Given this list of marker genes Pthlh (NCBI Gene Id 19227), Atf4, Slc39a8, Ache, Crb2, Dlk1, Sox6, Slc37a4, Dnaja3 (NCBI Gene Id 98023), Slc1a5, Zfp251, Cfap70, Prom1, Hdac6, Crtc3, Mir379, Picalm, Adam17, Ccl2, Fcgr2b, Atp1b2, Slc4a2, Acvr1c, Cdh23, Rac2, Mir134, Rps24, Mup11, Tspan9, Ctnnb1, Smad5, Stat5b, Prkaa1, Bmi1, Ogt, Gpr137b, Gpr183, Sit1, Ceacam1, Slc25a44, Tsc22d3, Jmjd6, Kdm6b (KDM1 lysine (K)-specific demethylase 6B), Prrc1, Lrp6, Car2, Kras, Mir140, Gpam, Actn3, Ehbp1l1, Naglu, Gnas, Smarca4, Sln, Bcr, Cebpg, Ebf2, Prcp, Gpr82, Acaca, Glul, Scnn1b, C1qtnf9, Neurod1, Nphp4, Elovl3, Skil, Adipoq, Gimap5, Zfp423, Stk11, Adora2a, Mir487b, Atf2, Ripk3, Anxa1, Hoxa5, Gprasp2, Nr1d1, Mthfd1, Cckar, Mak, Mpl, Nr1d2, Oas1c, Pemt, Kitl, Decr1, Acadvl, Muc4, Slc22a5, Plcl2, Ampd3, Hmox1, Epsti1, Tmem63b, Med1 (NCBI Gene Id 19014), Tlr9, Flvcr1, Plcl1, Ildr2, Mfsd2a, Igf2bp2, Zc3h8, Ppp2ca, Tnf, Pla2g2a (NCBI Gene Id 18780), Sod2, Rc3h2, Ppp1r13l, Gcnt2, Ptges, Arhgef5, Tmprss6, Nr1h2, Slc28a3, Stk39, Tnfrsf13b, Sh3gl2, Wnt10b, Ccr5 (C-C motif chemokine receptor 5), Nf1, Mir329, Smarca2, Myb, Adcyap1, Tnfrsf4, Ccl5, Mir412, Il1a, L3mbtl3, Siva1, Ank1 (ankyrin 1, erythroid), Nt5e, Abcb1a, Calcr, Rps6, Rhd, Pth2r, Acin1, Hoxc10, Il7, Slc27a1, Il15, Vps13b, Rassf2, Sos2, Stat4 (NCBI Gene Id 20849), Zbtb7b, Inpp5d, Nod2, Ireb2, Zbtb18, Spp1, Abhd6, Mir323, Epg5, Ltbp3, Slc22a21, Pnpla3, Add1, Lat, Col14a1, Hoxb6, Il6, Dyrk3, Ehmt1, Wfs1, Cdk5rap3, Sucnr1, Isg15, Minar2, Irf4, Kmt2a, Vpreb1b, Dll1, Wwtr1, Apc, Rrn3, P4htm, Etv2, Axin1, Jak2, Fmo4, Hfe, Dock11, Atxn2, Ercc2, Gfi1b, Ets1, P2rx7, Suv39h1, Emcn, Nox3, Mup3, Idua, Csf1, Ccr4 (C-C motif chemokine receptor 4), Ikbkb, Cd47, Ubap2l (NCBI Gene Id 97055), Tns2, Arap1, Rps19, Letmd1, Bbs2, Plac8, Exoc5, Hba-a2, Ceacam2, Rbp4, Spta1, Mir122, Hnf1a, Vgf, Col3a1, Adam8, Hbb-bs, Fcor, Lmo2, Cd44, Slc25a38, Pbld1, Slc46a2, Mir1197, Abcg2, Nkiras2, Ptgs2, Slc15a4, Mir485, Hamp, Bpgm, Cntn2, Afdn, Nkx2-3, Gpx2, Cxcr2, Akr1b1, Lsr, Hadh, Heatr3, Mir150, Cartpt, Cdhr1, Tfrc, Ddit3, Oas1g, Slc11a2, Mfn2, Ikbkg, Crocc, Fance (NCBI Gene Id 72775), Cdh2, Xiap, Tulp1, Ush1c, Gpr15lg, Eif4g1, Twist1, Brd1, Col2a1, Fech, Plcb1, Fbxo21, Adar, Aipl1, Slc48a1, Bmp4, B2m, Prlh, Lcn2, Septin4, Ascl3, Ccdc154, Rps14, Whrn, Nr1h3, Cpt2, Cfh, Tjp1, Ppp3cb, Acot13, Siglec15, Mir411, Abcb10, Atp5if1, Rps17, Inpp5k, Il20rb, Flt3l, Zfp36l1, Cngb1, Il20ra, Bpifa1, Inhba, Trf, Umod, Pacs1, Nova1, Fmo2, Adgrf4, Mtf1, Ndn, Alas2, Mfhas1, Il4ra, Aqp4, Aqp2, Prkdc, Akt3, Mir654, Acvr2b, Pirb, Trpv1, Sirt1, Mir666, Trim58, Ucp2, Pde6a, Itgb3, Bbip1, Acp5, Scnn1g, Cntnap2, Slc35d3, Bax, Mapk14, Pbld2, Gpr137, Nfe2l1, Il10ra, Mllt6, Bmp6, Cidea, Vegfa, Oas1a, Kdm3a, Hspa1b, Lep, Muc13, Clic5, Adgrg1, Racgap1, Ubash3b (NCBI Gene Id 72828), Pctp, Dync1h1, Alas1, Wdr48, Def8 (differentially expressed in FDCP 8), Ptgs1, Cxcr4, Atp6v1b1, Slc7a11, Ybx2, Htr2a, Itgam, Nr4a3 (NCBI Gene Id 18124), Bsg (NCBI Gene Id 12215), Fstl1, Esrrg, Mup1, Cadps2, Acadl, Mecom, Strap, Oxt, Wdr36, Foxa3, Mpig6b, Gpr55, Pknox1, Ezh2, Slc4a1, Dio2, Dnase2a, Adora1, Scd1, Ldb1, Rhag, Srf, Abcb1b, Stat5a, G6pdx, Rag1, Apbb2, Mir380, Ahr, Bap1, Mip, Dock10, Gimap3, Pik3ca, Il18r1, Mbl2, Ocln, Fcer1g, Gpx1, Selenow, Piwil4, Mrap2, Lrrk1, Lpcat1, Cx3cr1 (C-X3-C motif chemokine receptor 1), Cyp19a1, Gata3 (GATA binding protein 3), Card11, Ankrd54, Tnfrsf17, Gfral, Hmgb1, Spi1, Ankle1, Nckap1l, Tgfbr3, Nemp1, Mir541 (microRNA 541), Pla2g10, Oas1e, Zfp36, Map7, Prlr, Cd24a, Mir451a, Pdgfrb, Mir667, Ncstn, Tnfrsf13c, Ildr1, Iqcb1, Mir376a, Pla2g4a, Tnfsf4, Ppard, Emx1 (NCBI Gene Id 13796), Ahsg, Ednrb, Cib2, Mir1193, Cftr, Aqp7, Mir369, Nppb, Nova2, Syk, Guca2b, Hspa9, Cep290, Edn2, Bloc1s6, Has2, Adipor1, Ufl1, Oma1, Mafb, Ccdc66, Cytl1, Trgc1, Lama4, Sh2b2, Cd38, Tmem14c, Prdm14, Nxnl2, Ccr2, Gpr39, Kcnj1, Prdx2, Hif1a, Hjv, Ifnb1, Mir539, Ap3b1, Tfe3, Abcc8, Nbea, Ptger3, Pdgfc, Mir494, Bscl2, Mir453, Hcar2, Poc1b, Lca5, Ptpn2, Aqp6, Ccr7, Flcn, Gigyf2, Foxc2, Wnk3, Nos3, Kif3a, Abat, Nfkbiz, Sart3, Scnn1a, Col9a1, Rasal2, Ccdc198, Epb42, Mir496b, Il2ra (interleukin 2 receptor, alpha chain), Vhl, Gapt, Rcor1, Ampd2, Adipor2, Sash3 (SAM and SH3 domain containing 3), Itgb1, Hephl1, Hcrt, Il1b, Armcx1, Mir142hg, Fbxl5, Mir451b, Mc4r, Tub, Fam210b, Mkks, Per2, Erbb4, Fosl2, Exoc6, Ldb2, Gpi1, Zeb2, Nlrp6, Mir17, Bmp8b, Cln8, Gdf3, Rheb, Mir409, Nphp3, Dbh, Uba5, Zfp516, Mir299b, Foxp3, Pwwp2b, Rbfox2, Ctns, Myct1, Itpkb, Bbs10, Cdin1, Fsip1, Senp1, Apoe, Ubb, Tex15, Adamts5, Rab3d, Ghrl, Tgfb2, Bak1 (NCBI Gene Id 12018), Egr1, Cnot3, Fto, Klf13, Gm36723, Brinp1 (bone morphogenic protein/retinoic acid inducible neural specific 1), Mks1, Wnk4, Col11a2, Apln, Slc1a1, Mertk, C1qtnf4, Coro1a, Nrdc, Tcirg1, Btk, Gpr174, Abl1, Adrb1, Cldn5 (NCBI Gene Id 21920), Sox4, Crtc1, Bcl6, Adrb2, Notch1, Lmo1, Trim10, Clrn1, Btbd9, Nle1, Smo, Fmo1, Cav1, Fgf21 (fibroblast growth factor 21), Avp, Usp45, Ypel4, Vpreb1a, Men1, Sco1, Adcy6, Vstm4, Trpm8, Ppargc1a, Znhit1, Enpp1, Bola3, Ercc6, Col6a1, Rp1, Akt1, Sfxn5, Heph, Ankrd11, Odad3, Oas1h, Hba-x, Hc, Napepld, Vps13a, Bcl2l11, Pantr2, Pik3cd, Napsa, Gnasas1, Bdkrb2, Tle3, Pparg, Muc5ac, Perp, Caml, Prdx5, Irx3, Tspo2, Foxc1 (NCBI Gene Id 17300), Cxcl5, Grb10, Pgam5, Oas1b, Mfap2 (microfibrillar-associated protein 2), Mir376c, Fshb, Setd1a, Tpp1, Cybrd1, Fcgr4, Tcea1, Cxadr, Sfxn1, Fam3d, Tlr4, Trpv2, Rab7, Gba1, F2r, Creb1, Carmil2, Map2k6, Ext2 (exostosin glycosyltransferase 2), Oas1f, Slc11a1, Epo, Thra, Mir300, Pmaip1, Ctsk (cathepsin K), Lilrb4a, Ezh1, Tff2, Aqp3 (NCBI Gene Id 230080), Neo1, Ptk2b, Hmga1, Pth, Pdk4, Tmem64, Qki, Fancc, Ncor1, Mef2c, Il1rn, Rp1l1, Hcls1, Sod1, Ccnb2, Lyn, Prkab1, Smap1, G0s2, Ctss, Tnfsf11, Ncdn, Alms1, Sqstm1, Gdf15, Ppp2r3c, Adgrv1, Pkn1, Chst3, Acvr2a, Crispld1, Lepr, Zfp830, Fas, Cd36, Ahsp, Kit (NCBI Gene Id 16590), Mb, Nmu, Abcc6, Csf1r, Mc3r, Ift80, Fh1, Ikzf1, Cebpa, Rpa1, Itgb6, Ext1, Gadd45g, Dock7, Hoxa13, Ksr2, Tmem18 (NCBI Gene Id 211986), Elp6, Lgr4, Dhrs7b, Hmgb2, Ctsh, Tsku, Mir496a, Gcnt4, Mir410 (microRNA 410), Bcl2a1a, Nanos1, Mir758, Acsl1, Dmtn, Rmi1, Mir543, Gatm, Ip6k1 (inositol hexaphosphate kinase 1), Cbl, Yap1, Sorl1, Jam3, Il4, Ccn3, Cyld, Klhl10, Tal1, Norad, Tff3, Map1a, Cd7, Mir154, Afp, Tspan12, Fgf7, Zbtb7a, Elovl6, Gpr3, Il18, Prickle1, Muc2, Htt, Dram2, Diaph3, Id2, Il3, Chmp5, Rac3, Slc12a2, Jak3, Plekhm1 (pleckstrin homology domain containing, family M (with RUN domain) member 1), Il13, Tns3, Cldn18, Tmod3, Zfpm1, Traf3ip2, Pm20d1, Mlxipl (MLX interacting protein-like), Tfr2, Mcrip2, Klf2, Ush1g, Abcc1, Dcstamp, Sos1, Aldh1a1, Rac1, Metrnl, Pkp3, Rbpj, Clcn3, Tet2, Nox4, Bcl10, Ift88, Chmp4b, Tnfsf13b, Mir544, Slc28a2b, Sct, Mbl1, Cdh3, Cmklr1, Stat3, Ppargc1b, Ces1d, Mbp, Sp1, Comp, Prdx1, Abca12, Tshr, Cdk6, Gm15915, Il2, Htr4, Iapp, Vps54, Esrrb, Drd1, Tjp3, Mif, Abca3 (NCBI Gene Id 69158), Pth1r, Hscb, Rpe65, Akap11, Appl2, Trp53inp2, Kcnq1, Cd34, Nfix, Gnat2, Mir679, Kdr, Mir381, Pde4b, Trim32, Mup4, Cd74, Acvr1b, Crb1, Bpifa5, Traf6, Ptbp3, Fabp5, Vsig1, Alpl, Polb, Lgals2, Slc25a5, Hsf1, Bcl2, Bmal1, Adgrf5, Glis2, Cracd, Tcf3, Alk, Oas1d, Epas1, Sirt6, Tnfaip3, Bbln, Sctr, Arrdc3, Slc25a40, Angpt1, Sgip1, Stat1, Tff1, Slc40a1, Kdm1a, Lnpep, Ffar4, Card9, Kmt2e, Bbs4, Pask, Ank, Dlg1, Drd2, Gata2, Ppp2r1a, Trpv4 (NCBI Gene Id 80591), Pianp, Tbl1xr1, Mir376b, Slc2a1, Prmt1, Zfx, Maea, Gata1, Phox2b, Ptpn11, Csk, Tmem63a, Sprr2a1, Lyar, Il7r, Hdac3, Rho, Nkiras1, Lrrc19, G6pd2, Rcn3, Flt3, Bbs1, Tnfrsf11a (NCBI Gene Id 21934), Prkab2, Fabp4, Sftpd, Scx, Arsg, Wdr37, Slc39a3, Slc25a25, Prkaa2, Mir144, Igf1r, Mir382, Gja1, Slc28a2, Mir299a, Scrib, Fshr, Mtch2 (mitochondrial carrier 2), Nfib, Hyal2, Rb1, Mup2, Acot11, Mir495, Foxn1, Ntsr1, Eif2ak1, Mir668, Foxo3 (NCBI Gene Id 97633), Abca4, Tmem119, Sox9, P2ry14, Acacb, Ada, Bbs12, Aim2, Id1, Oscar, Rc3h1 (RING CCCH (C3H) domains 1), Aqp1, Mir125a, Rrp8, Bloodlinc, Tnfrsf11b, St6galnac1, Itgav, Inava, Oxtr, Klf1, Axl, Prdm16, Src, Pprc1, Spata7, Fadd, Mex3c, Cebpb, Cd2ap, Adrb3 (NCBI Gene Id 11556), Ifng, Spns2, Acbd7, Clstn3, Xkr8 (NCBI Gene Id 381560), Lipa, Pik3cb, Hba-a1, Cited2, Ucp1, Hnrnpu, Lpcat3, Arid4a, Pcsk1n, Il17a, Sp3, Pcdh15, Tgfb1, Mup5, Ccn2, Tuba1a (tubulin, alpha 1A), Ihh, Snx10, Rufy4, Stat6, Hamp2, Trpm2, Mapk8, Muc19, Prkca, Errfi1, Egfr, Lamp3, Asxl1, Ncapg2 (NCBI Gene Id 76044), Ptger4, Lpin1, Nxnl1, Nmur2, Atf1, Ush2a, Ndp, Casp3, Nfat5, S1pr1, Kat7, Tjp2, Cnr1, Npr3, Mir377, Sh2b3, here is a description of the gene set: Mouse Gene Set: GOBP_MULTICELLULAR_ORGANISMAL_LEVEL_HOMEOSTASIS Any process involved in the maintenance of an internal steady state at the level of the multicellular organism. species: Mus musculus